The following is a description of a gene set: Human Gene Set: NRF2_01 Genes having at least one occurrence of the motif ACCGGAAGNG in the regions spanning 4 kb centered on their transcription starting sites. This matches the GABPB1 transcription factor binding site V$NRF2_01 (v7.4 TRANSFAC). species: Homo sapiens, and this is the list of marker genes: UQCRH, TIMM8B, TRMT112, ZNF585B, LZIC, CLMN, FYCO1, SERBP1, NR1H2, DDOST, DDX39B, SYNRG, STK4, RNPS1, TBCC, CBX8, SDHD, SZT2, RAP2C, ZNF653, FAM174A, BCL2 (NCBI Gene Id 596), FMR1, TCF7, IQGAP1, ZNF322, MTF1, VPS52, UBE2F (ubiquitin conjugating enzyme E2 F (putative)), FBXO3, VMP1, ACIN1 (apoptotic chromatin condensation inducer 1), FRS2 (fibroblast growth factor receptor substrate 2), SIRT3, AP1M1, CCDC85B, PALB2, DAZAP2, ARHGAP1, EGR2, GNAI2, RPL34, ARHGAP4, MARK3, PHF6, PRKACB, PSMD12, UBA5, CPT2, AAAS, THAP10, ITFG1, HMG20A, DPP8, HERC4, MSANTD2, PRDX5, SDHAF2, FBXL9P, EIF2B2, BCL2L1, LRRC41, POMP, RPL27, U2AF1L4, DTX2, ALX3, KICS2, DCUN1D3, RPL37, TOMM70, UFC1, ARF3, MTMR4, E2F4, NOC2L, KMT5A, SEC11A, CRB3, CD2BP2, GNAI3, RPS5, FBXW9, MON1B, NMNAT1, LIN28A, MPZL3, BTAF1, USF1, RPL34-DT, ZNF384, SHC1, PHF23, ERCC1, WWP2, HNRNPLL, PSMD13, MEGF8 (NCBI Gene Id 90198), DDX5 (DEAD-box helicase 5), DDIT3, TMUB2, RAB1B, CHUK, MTPN, ZNF23, ZBTB26, MED8, GTF2A2, RGS19, TNFRSF1A, BAZ1A, UBA1, ZNF408, SF3B4, MTMR2, INTS13, INTS9, LYRM1, CSAD (NCBI Gene Id 51380), MLEC, ZNHIT1, ZFHX3, BATF2, ATP6V1D, INSIG2, EIF2S1, VPS53, SYVN1, PPME1 (protein phosphatase methylesterase 1), BCDIN3D, NKIRAS2, ACAD11, TSPAN31 (NCBI Gene Id 6302), SCAMP2, WDR74, FIBP, COQ10B, CWC25 (CWC25 spliceosome associated protein homolog), CSNK2B, ZNF22-AS1, TUFM, ING4, SCN4B, VAX1 (ventral anterior homeobox 1), PAFAH1B2, PYM1, HNRNPD, PHLDB3, ODAD3 (outer dynein arm docking complex subunit 3), SPTY2D1, STK11IP, RETREG2 (NCBI Gene Id 79137), LSR, PHKB, ACVR2A, RPS18, GNL2, ELK4, CPEB4, AKAP12, RPL6, AZI2, INTS3, RPS10 (ribosomal protein S10), AKT1S1, TNKS2, CSGALNACT2, ZBTB11, ARL5B, DLST, ZNF22, CUTC, NUDT21, RPL29, FGFR1OP2, NUDT5, TMEM208, TBC1D17, TM2D3, LRRC1, UHMK1, SRSF6, ZNF184, ZDHHC5, ACTR2, CNPPD1, PTRH2, PYROXD1, GTF3C1, GTSF1, DHX8, TOMM40, SZRD1, DRP2, LINC03124, ZBTB41, CKS1B, CEP95, UBXN1, ZNF687, MRPL3, UGGT2, DCTN5, EDC4, KLHL17, KDM5C, NF1, DR1, MTFR1L, B3GAT3, KAT5, HMBOX1, CELF1, CPSF7, SEC24C, CAP1, SRSF4, SENP1, TFCP2, EIF5A (eukaryotic translation initiation factor 5A), EIF3D, CTTNBP2NL, PLOD3, HSPH1, DDX50, NIPBL, DNMT1, DNAJC1, CDC123, EMG1 (NCBI Gene Id 619532), DIABLO, GSPT1, RGL1, EXOC5, TYMP, SLC6A14, AGL, RRAS, NRAS, TIGD6, EPN1, ITM2C, AP5M1, ARHGEF7, ARPC5, TMCO1, C14orf119, PHB2, ZNF689, RMND5B, SYT5, UBE2N, FBXO22, PRPF19 (pre-mRNA processing factor 19), KCNAB2, NLRC3, DAXX, ZNF585A, COX15, LRRC49, GPANK1, CHERP, ACP2, RAB25, SPINDOC, PSENEN, KTI12, TRIM44, TOMM22, DNAJC7, EDC3, BIN3 (bridging integrator 3), PRKCSH